The following is a description of a gene set: studied in species Homo sapiens Human Gene Set: GOCC_DESMOSOME A cell-cell junction in which: on the cytoplasmic surface of each interacting plasma membrane is a dense plaque composed of a mixture of intracellular anchor proteins; a bundle of keratin intermediate filaments is attached to the surface of each plaque; transmembrane adhesion proteins of the cadherin family bind to the plaques and interact through their extracellular domains to hold the adjacent membranes together by a Ca2+-dependent mechanism., and this is the list of marker genes: POF1B, DSC2, PPL, TCHP, DSC3 (desmocollin 3), JUP, PKP2, KRT80, DSP, KAZN, KLHL24, DSG1, CDSN, DSC1, JAM3, DSG4, PKP1, PERP, UBA1, B4GALT1, PKP4, DSG2, PKP3, CDH1, CTNNA3, EVPL, VCL, DSG3, XIRP1, CDH2, PNN